The following is a description of a gene set: Mouse Gene Set: REACTOME_STABILIZATION_OF_P53 species: Mus musculus Stabilization of p53, and this is the list of marker genes: Psmd8, Atm (NCBI Gene Id 77416), Psmb7, Psmb2, Psmd3, Psmd11, Rps27a, Psmc4, Cop1, Psmb4, Ubb, Adrm1, Psmc2, Psmd1, Psma4, Ubc, Trp53, Psma1, Psma3, Psmd12, Psmd7, Uba52rt (NCBI Gene Id 676687), Psmb1, Phf20, Psmd6, Psma6, Psma7, Psmc5, Chek2, Psmc1, Psmc6, Mdm4, Psmc3, Psmb5 (proteasome (prosome, macropain) subunit, beta type 5), Psmd2, Mdm2, Psmb6, Psmd14, Uba52, Psma2, Psma5, Psmd13, Psmb3